Given this list of marker genes Igfbp3, Igf2r, Igfbp6, Igfbp5, Igfbp2, Igfbp1, Igfbp4, Insr, here is a description of the gene set: species: Mus musculus Binding to insulin-like growth factor II. Mouse Gene Set: GOMF_INSULIN_LIKE_GROWTH_FACTOR_II_BINDING